The following is a description of a gene set: Human Gene Set: HP_BROAD_COLUMELLA Increased width of the columella. Broad columella species: Homo sapiens, and this is the list of marker genes: ZSWIM6, PPP1R21, RPS6KA3 (NCBI Gene Id 6197), H4C5, RDH11, EXOSC2, FLI1, HDAC4, GJA1, ALX4, PIK3C2A, ATP6V1E1, CWC27, CKAP2L